Given this list of marker genes Col18a1, Magea7-ps, Clec2l, Scaper, Dsg2, Clip4, Zkscan2, Fgf15, Arfrp1, Vnn1, 1110002L01Rik, Arhgef10, Castor2, 1810008B01Rik, Hbegf (heparin-binding EGF-like growth factor), Rbp1, Egr3, Lamb2, Prrx1, Spata7, Ighe, Chst2, H13, Phlpp1, Ift43, Igf1r, Stx1b, Ldhal6b, Rnf151, Adarb1, Ldb2, Zmynd11, Tuba3a, Jag2, Rcc2, Pln, Hoxa10, Zranb1, Mecom, Crim1, Nmt1 (N-myristoyltransferase 1), Fam168a, Zfp268, Marchf10, Hsd3b3, Rora, Myo5c, Adgrd1, Pclo, P2rx4, Havcr1, Gm12359, Prr16, Utrn, Traf1, 4933438K21Rik, Gdap1, Ift122, Slc16a9, Fmn2, Bace2, Hoxb5os, St8sia4, Nfe2l3, Syn2, Ccser1, Dnm1, Prox1, Slc9b2, Lix1l, Six5 (sine oculis-related homeobox 5), Tinf2, Zbtb39, Npy1r, 1700061F12Rik, Krt7, Naa30, Zfp784, Rasal2, Gbp6, Sprr1a, Atxn1, Plscr4, Chic1, Wfdc17, Zdhhc17 (zinc finger, DHHC domain containing 17), Lpp, E330013P04Rik, Krt27, Zfp260, Hoxa3, Pcgf2, Tmem144, Zan, Efna4, Fstl1, Cgnl1, Angpt1, Hlf, Smim17, Zmym6, Ext2, Map7, Zfp1, Zkscan1, Scarf1, 2610008E11Rik, Nt5dc3, Bcl9l, Pcdh9, Elapor1, Lce1k, Ufsp2, Garin5a, Smyd3, Bach2it1, D630039A03Rik, Stard6, Gm16638 (NCBI Gene Id 102631889), Mboat2, Nbea (neurobeachin), Cilk1, Srgap1, Akap9, Gm36839, Ott, Filip1, Shroom3, Ptprz1, Ccl27a, Gprc5b, Procr, Mast2, Cntn1, Lrch4, Cerox1, Ankzf1, Gm10857, Gjd2, Ocln, Kazald1, Adgrl1, Lca5, Fkbp7, Myom1, Dusp15, Ceacam13, Lhx9 (NCBI Gene Id 98737), Ccdc112 (coiled-coil domain containing 112), Gm5907, Cldn3, Plxdc2, Cyp2j9, Jam3, Padi6, Kif6, Prrt3, Adam22, Cbx7, Csad, 4732465J04Rik, Slc6a15, ENSMUSG00000134760, Ablim1, D930048N14Rik, Tie1, Akr1c21, Flrt3, Gm2a, Cavin3, Dcaf6, Gnas, Il4, Bicc1, Tsbp1, Rhoq, Epha5, Ttll7, Leng8, Ptpn21, Synpo, Srgap3, Ak1, Mga, Met, Ski, Anks1b, 4931406C07Rik, Efnb2, Eya2, Epb41l2, Gm5124, Mucl2, Large1, Zfp92, Zbtb20, Sprr2a1, 9830004L10Rik, Prdm16, Zfp354a, Foxn3, Rras, Fut10, Nsrp1, Setbp1, Faah, Bend5, Scp2d1, Hes1, Ccm2l, Rorc, Tnfrsf8, Zfp467, Rab33a, Kdf1, Kndc1, Tcf7l1, Pcdh1, Gaa, Aqp4, Slc12a2, Bmp8a, Hp1bp3, Hoxa5, Gla, Pierce1, Pbp2, Sltm, Lgi3, Ccdc71, Tns1, Prdm1, Psg19, Dyrk4, Elavl4, Twist2, Jam2, Cacna1c, Dock9, Vdr, Cbx6, Lactb, Dock8, Gm12860, here is a description of the gene set: Genes in the expression cluster 'LT-HSC Shared': up-regulated in long term hematopoietic stem cells (LT-HSC) from adult bone marrow and fetal liver. from publication Ivanova NB, Dimos JT, Schaniel C, Hackney JA, Moore KA, Lemischka IR (PMID 12228721) Mechanisms regulating self-renewal and cell fate decisions in mammalian stem cells are poorly understood. We determined global gene expression profiles for mouse and human hematopoietic stem cells and other stages of the hematopoietic hierarchy. Murine and human hematopoietic stem cells share a number of expressed gene products, which define key conserved regulatory pathways in this developmental system. Moreover, in the mouse, a portion of the genetic program of hematopoietic stem cells is shared with embryonic and neural stem cells. This overlapping set of gene products represents a molecular signature of stem cells. studied in species Mus musculus Mouse Gene Set: IVANOVA_HEMATOPOIESIS_STEM_CELL_LONG_TERM